The following is a description of a gene set: Mouse Gene Set: GOBP_HETEROTYPIC_CELL_CELL_ADHESION The attachment of a cell to a cell of a different type via adhesion molecules. studied in species Mus musculus, and this is the list of marker genes: Itgax, Ager, Cd2, Dsg2, Jup, Fgg (NCBI Gene Id 99571), Gcnt2, Cd200l2, Nrcam, Madcam1, Lck, Itga5, Cd44, Ctnna3, Itgad, Ninj1, Perp, Itgb7, Itgav, Bmp7, Itgb2l, Dsp, Fga, Rnase10, Thy1, Cd200r1, Myadm, Flot1, Itga4, Nfasc, Il1rn, Mapk7, Map2k5, Wnk1, Klf4, Gldn, Adipoq, Mbp, Tnfaip3, Il1b, Itgb3, Itga7, Cd200, Tnf, Apoa1, Cd200l1, Dsc2, Itgb2, Vcam1, Jam3, Alox15, Parva, Izumo1 (NCBI Gene Id 73456), Pkp2, Ptprc, Cxadr, Il10, Itgb1, Skap1, Fgb